Given this list of marker genes Bckdk, Ivd, Hmgcl, Hmgcll1, Bcat1, Dao (D-amino acid oxidase), Auh, Bcat2, Mccc1, Mccc2, here is a description of the gene set: Mouse Gene Set: GOBP_L_LEUCINE_METABOLIC_PROCESS studied in species Mus musculus The chemical reactions and pathways involving L-leucine, 2-amino-4-methylpentanoic acid.